The following is a description of a gene set: Any process that modulates the frequency, rate or extent of trans-synaptic signaling. Human Gene Set: GOBP_REGULATION_OF_TRANS_SYNAPTIC_SIGNALING species: Homo sapiens, and this is the list of marker genes: STX4, LARGE1, CHRM1, PTK2B, CHRNA6, S100B, PRKCE, MEF2C, RAB5A, GRIK4, MIR342, SYP, FLOT1 (flotillin 1), MECP2, BRSK1, SLC6A6, UNC13C, MIR95, SLC6A9, SNCAIP, MAP1B, STAT3, CYFIP1, SHISA6, MAPK1, MPP2, CACNG5, LILRB2, MICU3, NPAS4, SYT13, PLCB1, CA2, ZDHHC3, SYBU, DRD2, P2RY1, APP, YWHAH, FER1L5, NOG, PRKCZ, ADORA3, SLC38A2, SSH1, EPHB1, GRIN2B, DKK1, CHRDL1, NTF3, SHANK3, JAK2, GLRA3, SHANK1, CALHM2, NEFH, CAMK2D, PPFIA2, SLC4A8, FBXO45, DISC1, ABL1, TNF, ADORA1, NEFL, RAP1A, SHANK2, NEO1 (neogenin 1), SIPA1L1, SYT11, SYT1, SLC38A1, NLGN3, RAPSN, HDAC6, SLC8A3, DRD3, ZDHHC12, CACNA1B, STX1B, NRG3, BSN, CRHR2, RTN4, LZTS1, BRAF, MIR320D2, SYN3, GPR151, SCTR, DAG1, RGS4, MTMR2, SNAPIN, RAP1BL, CAMK2G, TRIO, PLAT, LRRTM2, PMCH, NPY, WNT3A, SYT4, LGI1, CA7, RGS14, KCNQ3, AKAP7, TAC1, CACNA2D2, ASIC1, GRIK3, NEURL1, SHISA8, PTN, CBLN1, RAB3GAP1, NRXN2, GSG1L, MIR320E, SLC24A2, NSMF, NXPH1, SHISA9, CBLN4, GUCY1A1, ACE, MIR541, NETO1, RETN, BAIAP2, GPR158, CHRNB3, GRID2IP, CNTN2, YWHAG, VAMP2, SLC18A3, TPRG1L, GRM5, CACNG4, TUBB2B, WNT7A, CDH11, APOE, CACNA1A, CD38, GRM6, NTF4, SLC7A11, NPY2R, MDM2, FMR1, ATP2A2, PPFIA3, NLGN1, WNT5A, STX3, MIR320B1, ARHGAP44 (Rho GTPase activating protein 44), S1PR2, SLC1A3, MAPK9, PENK, LGMN, PCDH17, MIR545, NSG1, ADRB2, PTPRD, SHISA7, CREB1, SNCG, TSPOAP1, DGKE, PHF24, JPH4, TACR1, NGFR, APBA2, ABHD6, CHRNB4, RIMS2, NF1, PRKAR2B, PTPRS, DTNBP1, KIT, CACNG8, NEUROD2, SYNGR1, HTR2A, BCR, SLC6A4, GNAO1, ADORA2A, GFAP, DLGAP1, PPP3R1, CAMK2B, GIPC1, EIF4E, VPS35, FYN, AKAP12, PRKN, ATG5, NTNG1, YTHDF1, STXBP1 (syntaxin binding protein 1), MME, CAMK2A, CALM2, CPLX1, GABRR1, OTOF, GRIA3, GRIA4, CHRM2, UCN, ADRA1A, RAB3A, CNTNAP4, GRM7, SV2B, TACR2, STAU1, GSK3B, NLGN4X, CHRNA5, NR2E1, RIMS3, GGCX, PCDH8, RAPGEF2, MIR320C2, PRKACA, CALM3, ACHE, CNR2, SYT5, SCT, CUX2, EIF2AK4, RAB8A, PLCL2, CPLX3, ITGB1, MAPK3, NTRK2, IGF1, CX3CR1, PRKCG (NCBI Gene Id 57013), ARF1, ITPR3, GRIA2, DLGAP3, SLC7A10, KCNMB4, LRFN2, SLC1A1, AGER, RARA, ACP4, GRIK1, RASGRF2, CHRNA3, CACNG7, KCNK2, MAPK8IP2, DLGAP2, ARC, SLC24A1, MCTP1, KCTD13, CALB1, CD2AP, CELF4, SRF, GPER1, GHRL (ghrelin and obestatin prepropeptide), CX3CL1, RAC1, GRIN3A, HCN1, CPLX4, SNAP25, MCTP2 (NCBI Gene Id 55784), CALM1, SLC12A2, BTBD9, CRH, FAAH, ADCY8, HRAS, NCDN, SORCS3, PDE9A, GNAI2, PACSIN2, SYT7, RIMS4, CLSTN2, NMU, NPTN, NRXN1, EDN1, CAMKV, TMEM108, TYROBP, PTEN, MIR320A, SQSTM1, NRGN, RAP1B, STAU2, PRKAR1B, BDNF, LAMP5 (lysosomal associated membrane protein family member 5), LRRC4, FBXL20, KMO, ATP1A2, DLG4, CACNB4, SYT12, VPS13A, SEPTIN5, KCNB1, NLGN2, BAIAP3, MIR421, ATAD1, SYT2, KAT2A, LRRTM1, BCHE, SLC8A2, EPHA7, NPY5R, SNCA, PFN1, LRRC4C, GRM4, CBLN2, VGF, GRIN2A, KCNJ10, BACE1, ZDHHC2, VPS18, SLC4A10, LRP8, P2RX3, USP46, DCC, CCL2, ARRB2, ABR, USP8, SYNGAP1, RELN, ANAPC2, CNTN4, PLCL1, SNX14, ADIPOQ, MAPT, MIR433, CSPG5 (NCBI Gene Id 10675), FXR1, NGF, HMGCR, MIR320C1, OPHN1, C22orf39, PRRT2, ADCY1, PRRT1 (NCBI Gene Id 80863), ADRA2A (adrenoceptor alpha 2A), KMT2A (lysine methyltransferase 2A), TBC1D24 (NCBI Gene Id 57465), NPS, RASGRF1, CHMP2B, NTRK1, PAFAH1B1, JPH3, CPEB3, GABBR1, GRIA1, SLITRK4, DYSF, PNKD, P2RX1, NTNG2, GRM3, CLSTN1, FABP5, BEST1, EPHB2, DVL1, RAB11A, INA, STX1A, IQSEC2, CDK5, IL1B, GRIK2, GHSR, HIP1 (huntingtin interacting protein 1), CLN3, NFATC4, MIR142, ZDHHC17, CASK, CYP46A1, CPLX2, GRID1, STXBP5, ADGRB1, CACNG2, NRN1, GRIN2D, PICK1, PFN2, GLRA2, LAMA2, UBE2I, BGLAP, MIR320B2, NXPH4, CHRNB2, SLC30A1, F2R, MYOF, AKAP5, TMEM25, SYN1, CLSTN3, CACNG3, RPS6KB1, DMPK, SLITRK5, PREPL, DRD5, PRNP, NCSTN, CCR2, ITPKA, SORCS2, FRRS1L, GRIK5, TSHZ3, CALB2, KIF5B, OXT, DBN1, PLK2, GRM2, CDH1, PMCHL2, PLG, PPP3CA, TNR, PPP1R9A (protein phosphatase 1 regulatory subunit 9A), CDC20, CNRIP1, GRM1 (NCBI Gene Id 2911), PINK1, HRH1, RNF167, NALCN, MIR324, GRID2, APBA1, ZMYND8, CHRNA7, GRM8, GRIN1, SERPINE2, DRD1, PAIP2, HOMER1, IGSF11, CDKL5, FXR2, CLMP, HAP1, HCRT, GRIN2C, GIT1, INS, EPHA4, ATF4, DLGAP4, MIR320D1, UBE3A, ADNP, PPP3CB, UNC13A, CFL1, EIF4A3, GRIN3B, EFNB3, SYAP1, PXK, FAM107A, FBXO2, SV2C, PSEN1, PRKCB, SYT8, EIF4EBP2, ADORA2B, IGSF21, RIMS1, KRAS, PLPPR4, LRRK2, MIR30B, MAP1A, MIR337